Given this list of marker genes PIP5K1A (phosphatidylinositol-4-phosphate 5-kinase type 1 alpha), TCEAL1, LMOD1, U2AF2, VPS26A, ASIC1, CS (citrate synthase), EPC1, CIZ1, TAOK2, KDM3B, RUNX1T1, ASB11, TMEM60, PDZRN4, DVL2, RNF115, CADPS, ATP6V0D2, ACTMAP, ATP6V1A, CLN3, GLRA2, MOSPD1, GLMP, RGL1 (NCBI Gene Id 23179), PLS3, RAB5B, ARMCX6, SDF2 (stromal cell derived factor 2), PWWP2B, HK2, RPP25L, PTGR3, GTF2H1, SPPL3, JPH1, PEX5L, UBE2V1, AKAP12, DUSP8, BLOC1S1, STC2, ATRX, RNF14, TENM3-AS1, SLC35A5, MMAA (metabolism of cobalamin associated A), C2, LRRC4, TRMT1, MAP2K5, CTNS, MARCHF8, LCP1, MSI2, SRSF2 (serine and arginine rich splicing factor 2), CALR, KAT14, BLM, PCYT2, SYTL2, STARD3, TLCD5, MBD6, RABEP1, SNX33, ORC6, TMEM199, NTMT1, GBA2, TP53BP1, MFSD5, GSK3B, USH1G (NCBI Gene Id 140471), FAM50A, MOCS3, ALS2, TMEM151A, SAE1, CUL5, CLCN5, PNOC, CISD1, TDG, ACTG2, XPO4, ENPEP, OXCT1, GIPC1, WBP2NL, SOX10, LARP4, AHCYL1, ATL2, UVRAG, CHD2 (NCBI Gene Id 283680), CMYA5, FEZF2, CITED2, VPS35L, VPS18, NFE2L1 (NFE2 like bZIP transcription factor 1), RAD9A (RAD9 checkpoint clamp component A), GAB2, VPS41, GABARAP, PPCS, CGGBP1, DIP2B, GPR15, MAFF, LDHAL6B, STT3A (STT3 oligosaccharyltransferase complex catalytic subunit A), BRAF, PLXNA2, PTPRF, DLX2, SLC66A1, NFIB, ARMCX3, CHMP2B, DDR2, RALYL, ILVBL, PPT1, HECTD4, NSMCE2, NPEPPS, COMMD9, MBD5, HAS2, IL17A, PDE7A, KRTAP9-2 (NCBI Gene Id 83899), OTOP2, DAZAP2, HPS5, TMEM126B, SOX5, STX4, SUPV3L1, LMNTD1, SMOC2, APP, TRPM7, NOL4, TUB, HOXD4, PICALM (NCBI Gene Id 8301), SPIN1, ETV3, TMCC2, SLC49A4, SLC3A2, BCL7A, DDIT3, MYOZ3, GRN, TRAPPC8, SLC30A3, SEC24D (SEC24 homolog D, COPII coat complex component), CNTF, KDM2A, BEX1, TMEM258, NEURL2, NALF2, ACP2, RBFOX2, NEUROD6, ANXA9, HMOX1, CRABP2, TGIF1, ZBTB8OS, RAB27A, PSENEN, ATP1B4, RNF185, PRKCE, PMEL (NCBI Gene Id 8088), ALDH6A1, PEPD, LNPK (lunapark, ER junction formation factor), GGN, RENBP, ARPC5, EIF4G1, CSF2, RAB22A, UBE2B, LRGUK, IL1RAPL2, CNPPD1, HOXC6, FOXP3, TCEAL3, HOXB4, ESCO1, ZNF367, HOXA2, MICU1 (NCBI Gene Id 51415), LMO3, ATXN7L2, OGDHL, ATF2, IGSF21, CTCF, POLDIP2, TTC16, TOLLIP, EPN3, SH2D6, TNPO2, SHPK, CREB3L1, R3HDM2, CRCT1, SIDT1, PLAAT3, SOCS2, CHM, MBNL2, ANKRD17, LY6G6D, PDP2, ATP6V1D, SLC35F6, RGS1, RASGRF1 (NCBI Gene Id 9983), UCP3, CAPN3, PDCD6IP, MCOLN1, ADAM11, SLC17A8, ZNF827, GIT2, BAX, RBBP4, HSPBAP1, NAA50, STAG1, DUSP3, POLR3C, BEX3, VPS35, PDGFB, SKIDA1, GTPBP2, MAP3K11, AS3MT, FOXP1, TCEAL9, STAG2, RTN4 (NCBI Gene Id 57142), GPR61, APEX1, ZNF207, SDHC, RPL28, SOX14, STK16, KAT5, CD5L, WDFY1, SNX16, CD109, LMTK2, C1orf43, ZNF547, AP3D1, MCF2, SMNDC1, BLNK, HEXA, GEM, PPARGC1A, NACC1, CUTA, LUM (NCBI Gene Id 4060), FBXO32, NCBP3, ALOX5, WNT3, SNX2, NYAP1, TMEM156, ATP6V1F, TOP3A, SRC, FAM13B, RNF146 (ring finger protein 146), SIRT1, PIAS4, EIF2S1, PDZK1, RORB, FEN1, TLR4, HPS3, STT3B, MANBA, KLHL32, HNRNPH2, PHYHIP, AKR7A2, ILF3, CYSTM1, NR1H4, S100A16, KAT7, DLX1, KIT, BCL9L, CTSD, VAC14, TFAP4, IGF2R, AARS1, TRIM55, DDR1, TOPORS, DNM1, LIPG, CLNK, IL1RAPL1, CDK2, TM4SF19, LAMP1, FUT11, ITPRIP, NFIX, NR1D1, ACTN1, ZDHHC13, GATB, CHN1, EIF4B, GET3, UBE4B, GPNMB, RCC2, CBX6, PAX2, YY1AP1, CSF3, SLC24A5, TADA1, SYNGR1 (synaptogyrin 1), ZFYVE26, PCM1, GNB2, NR4A1, SWAP70, GPATCH3, EME1, U2AF1L4 (NCBI Gene Id 8176), YTHDF3, MRPL27, EEF2, NR5A2, PURA, LRRN1, KLHL24, ATP6V0D1, ABR, SUPT16H, VGLL4, PKN1, LINC02880, SH3RF2, ATP6V1B2 (NCBI Gene Id 526), MID1, UBE2W, TPP1, ATP6AP1, TYR, XYLT2, CYP27A1, OSGEP, CFAP54, RFTN2, CAMK2D, ZIC3, FSHR, CAMKK1, CTSS, HIVEP1, NEUROD2, KCNAB1, NAP1L5, HOXC5, ZFYVE1, DCTN4, SLC38A7, SLC36A1, RAB26, BDNF, ITSN2, ADO, AFF4, KLF12, ZNF775, ATP6V1C1, SETD2, ADCY8, RETREG2, STARD3NL, ATP6V0C, DLG3 (discs large MAGUK scaffold protein 3), BLCAP, MACROH2A1, LAMTOR1, TUG1, HIF1A, MAF, TCEAL8, RAP1GAP, NAPA, MINDY2, SPNS1 (SPNS lysolipid transporter 1, lysophospholipid), FBXO36, ZMYND12, HTR5A, VGLL3, EYA1, ARHGEF12, CSRNP3 (cysteine and serine rich nuclear protein 3), SORBS3 (sorbin and SH3 domain containing 3), TOM1, BMP7 (bone morphogenetic protein 7), ILF3-DT, RNF181, EFCAB13 (NCBI Gene Id 124989), ASXL2, CD164, UBQLN1, PRR14L, RXFP1, S100A1, STX6, SLC6A20, RRAGC, HOXD3, RPH3A, SMCR8, RARB, SUPT6H, PTGFR, REL, PSAP, SNRPA, HYPK, GIGYF2, CDH12, ATP7A, FUCA2, USP31, LAMA3, TCEAL7, ASPSCR1, RAPGEF6, CTSA, JOSD1, APOA2, LRRC39, RAB3A, CBFA2T3, GAL3ST3 (NCBI Gene Id 89792), CDH16 (cadherin 16), QTRT1, VPS11, SV2A, RANBP10, GLA, TRIM63, ZNF462, here is a description of the gene set: from publication Xie X, Lu J, Kulbokas EJ, Golub TR, Mootha V, Lindblad-Toh K, Lander ES, Kellis M (PMID 15735639) Genes having at least one occurrence of the highly conserved motif M18 TCANNTGAY in the regions spanning 4 kb centered on their transcription starting sites. This matches the SREBF1 transcription factor binding site V$SREBP1_01 (v7.4 TRANSFAC). species: Homo sapiens Comprehensive identification of all functional elements encoded in the human genome is a fundamental need in biomedical research. Here, we present a comparative analysis of the human, mouse, rat and dog genomes to create a systematic catalogue of common regulatory motifs in promoters and 3' untranslated regions (3' UTRs). The promoter analysis yields 174 candidate motifs, including most previously known transcription-factor binding sites and 105 new motifs. The 3'-UTR analysis yields 106 motifs likely to be involved in post-transcriptional regulation. Nearly one-half are associated with microRNAs (miRNAs), leading to the discovery of many new miRNA genes and their likely target genes. Our results suggest that previous estimates of the number of human miRNA genes were low, and that miRNAs regulate at least 20% of human genes. The overall results provide a systematic view of gene regulation in the human, which will be refined as additional mammalian genomes become available. Human Gene Set: TCANNTGAY_SREBP1_01